Given this list of marker genes Riok2, Rps14, Tsr3, Gtf2h5, Nop9, Ngdn, Tsr1, Heatr1, Ddx52, Nol10, Slx9, Rps28, Rrs1, Utp3, Kri1, Rcl1, Nob1, Dcaf13, Pwp2, Abt1, Ercc2, Nol7, Rps21, Tsr2, Rps8, Rpp40, Utp6, Riok3, Utp25, Bms1, Nop14, Rrp36 (NCBI Gene Id 224823), Fcf1, Dhx37, Nat10, Bysl, Rps16, Nol11, Wdr43, Riok1, Trmt112, Srfbp1, Wdr3, Lsm6, Tbl3, Snu13, Utp23, Wdr46 (WD repeat domain 46), Rps19, Utp4, here is a description of the gene set: Mouse Gene Set: GOBP_MATURATION_OF_SSU_RRNA Any process involved in the maturation of a precursor Small SubUnit (SSU) ribosomal RNA (rRNA) molecule into a mature SSU-rRNA molecule. species: Mus musculus